Given this list of marker genes SEMA3B, SLITRK4, CELSR2, PCDHAC2, GRB14, ADAMTS13, TTBK1, EIF2AK1, DVL3 (dishevelled segment polarity protein 3), PCDHA5, SOD1, ERCC6, WDR77, MAPT, PTK2 (protein tyrosine kinase 2), UBP1, NAE1, LGR6, TNFSF10, API5, MAP2K5, PDCD2, ABCC4, CSF3, CEBPG, HYAL1, NR1H3, PHLDA2, FCHO1, PCDHGA12, GSTM3, TSPAN5, CSNK2A1, CYP19A1, GTF2H1, DHRS2, SPP1, PCDHA12, NLRP1, PPARD, CLK4, SVIL, COL9A3, ERGIC1, EIF4G2 (eukaryotic translation initiation factor 4 gamma 2), here is a description of the gene set: studied in species Homo sapiens Down-regulated genes displaying alternative splicing in MDA-MB-435 cells (breast cancer) whose metastatic potential has been reduced by expression of NME1. from publication Lee JH, Horak CE, Khanna C, Meng Z, Yu LR, Veenstra TD, Steeg PS (PMID 18245461) Human Gene Set: LEE_METASTASIS_AND_ALTERNATIVE_SPLICING_DN The role of Gemin5 in alternative mRNA splicing, tumor cell motility, and proteomic instability was investigated. Isotope Capture Affinity Tag proteomic analysis was conducted on MDA-MB-435 tumor cells transfected with either a control vector (C-100) or the Nm23-H1 metastasis suppressor (H1-177). Ingenuity pathway analysis revealed that RNA posttranscriptional processing was the most prominent class of differentially expressed proteins. Within this category, overexpression of Acinus1, Poly(a) binding protein, HNRPA2B1, Bop1, and Gemin5 was confirmed in less metastatic H1-177 cells. Overexpression of the latter four proteins was also observed in the lower metastatic antisense Ezrin transfectant of a murine osteosarcoma model system, confirming the general relevance of the trends. Gemin5, a component of the spliceosomal complex, was chosen for further study. Analysis of global mRNA splicing by SpliceArray chips revealed that genes were differentially spliced in C-100 compared with H1-177 cells; transient transfection of gemin5 into C-100 cells restored the splice pattern to that of H1-177 cells. Alternative splicing patterns for the engulfment and cell motility 1 and thrombospondin genes were confirmed by semiquantitative reverse transcription-PCR. Gemin5 overexpression coordinately reduced C-100 cell motility by 50%, and siRNA-mediated reduction of Gemin5 expression increased the motility of H1-177 cells by 2-fold (P < 0.004). The data provide the first demonstration that alterations in the expression of a spliceosome protein can effect both specific splicing events and tumor cell motility. The data also show that changes in mRNA splicing patterns accompany metastatic progression, which may contribute to proteome instability.